Given this list of marker genes EPM2A, ABCD1 (ATP binding cassette subfamily D member 1), AARS1, PSAP, SHQ1, ISCA2, NHLRC1, PLA2G6, PEX2, ARSA, LNPK, POLG, IFT56, here is a description of the gene set: Human Gene Set: HP_VEGETATIVE_STATE The absence of wakefulness and consciousness, but in contrast to a coma, there is involuntary opening of the eyes and movements such as teeth grinding, yawning, or thrashing of the extremities. Vegetative state studied in species Homo sapiens